Given this list of marker genes Pnliprp2, B3galt2, Fa2h, Ugt8a, B4galt3, B3galt1, Gal3st1, Galc, Psap, here is a description of the gene set: Mouse Gene Set: GOBP_GALACTOLIPID_METABOLIC_PROCESS The chemical reactions and pathways involving galactolipids, any glycolipid containing one of more residues of galactose and/or N-acetylgalactosamine. species: Mus musculus